The following is a description of a gene set: species: Mus musculus Mouse Gene Set: GOMF_TYPE_II_TRANSFORMING_GROWTH_FACTOR_BETA_RECEPTOR_BINDING Binding to a type II transforming growth factor beta receptor., and this is the list of marker genes: Tgfbr3l, Tgfb2, Tgfbr3, Amh, Eng (NCBI Gene Id 99055), Cd44, Tgfb3, Map3k7, Tgfbr1, Tgfb1, Lrg1